The following is a description of a gene set: species: Mus musculus Mouse Gene Set: GOBP_NEGATIVE_REGULATION_OF_CALCIUM_ION_TRANSPORT Any process that stops, prevents, or reduces the frequency, rate or extent of the directed movement of calcium ions into, out of or within a cell, or between cells, by means of some agent such as a transporter or pore., and this is the list of marker genes: Tgfb1, Dysf, Atp1a2, Ppp3r1, Sln, 1810037I17Rik, Gsto1, Cbarp, Tmbim6, Hrc, Ubqln1, Calm2, Crhr2, Trdn, Vdac1, Zfas1, Eppin, Spink1, Casq2 (calsequestrin 2), Drd4, Cav1, Ubr3, Pkd2, Ahr, Ptger3, Drd2, Cacna1f, Pln, Gnao1, Sestd1, Trim27, Rem1, Ntsr1, Ucp2, Epo, Ptgs2, Hes1, Pawr, Slc30a1, Tgfb2, Usp2, Mcub, Nos3, Bin1, Ywhae, Akt1, Ppp3cb, Smim6, Calm1, Prkce, Gpr35, Sri, Bcl2, Gstm7, Nos1, Stc1, Mrln, Ppp3cc, Fcrl5, Ppp3ca, Ppp3r2, Calm3, Tlr9, Fmr1, Pacsin3, Ace, Cav3, Icam1, Inpp5k, Gnb5, Wfdc6a, Fkbp1b, Fbxo11